Given this list of marker genes Hamp, Abcg8, Abcg5, Abcg2, Isx (intestine specific homeobox), Hamp2, here is a description of the gene set: studied in species Mus musculus Any process that stops, prevents or reduces the frequency, rate or extent of intestinal absorption. Mouse Gene Set: GOBP_NEGATIVE_REGULATION_OF_INTESTINAL_ABSORPTION